Given this list of marker genes Terf1, Piwil1, D1Pas1, Fance, Mlh1, Topaz1, Piwil2, Xrcc5, Mei1, Ube2b, Spo11, here is a description of the gene set: The cell cycle phase which is the first stage of M phase of meiosis and mitosis and during which chromosomes condense and the two daughter centrioles and their asters migrate toward the poles of the cell. Mouse Gene Set: GOBP_PROPHASE species: Mus musculus